The following is a description of a gene set: studied in species Homo sapiens Human Gene Set: REACTOME_REGULATION_OF_KIT_SIGNALING Regulation of KIT signaling, and this is the list of marker genes: FYN, SH2B3, LYN, CBL, SOCS1, SH2B2, SOCS6, YES1, PRKCA, PTPN6, GRB2, SOS1, KIT, LCK, KITLG, SRC